Given this list of marker genes VEZF1, TMPO, SLC4A1, GATA6, CBS, TNNT2, NKX2-5, PRDX1, DMD (dystrophin), TAF1A, ACTN2, SGCD, TCAP, FLNC, KCNN4, JAK2, MYH7, SCN5A, LMOD2, ABCC9, MMACHC, CITED2, TTR, KCNJ2, MYL4, KCNQ1, TPM1, MYPN, SERPINC1, HABP2, NUP155, LMNA, GET3, LDB3, PSEN1, DES, DSP, GATA5, HRG, KCNE2 (potassium voltage-gated channel subfamily E regulatory subunit 2), GATA4, PIEZO1, PRKAR1A, SDHA, TNNI3, RAF1, KCNE1, F13A1, TLL1, ADA2, FKTN, KIF20A, MYH6, PPCS (phosphopantothenoylcysteine synthetase), RPL3L, SCN3B, GJA5, EPOR, KCNA5, NKX2-6, DOLK, HAND2, BAG3, F2, UBA1, CAP2 (NCBI Gene Id 10486), TTN, ANKRD1, SCN4B, BAG5, RBM20, DSG2, KCNJ5, CSRP3, TAFAZZIN, PRDM16, LAMA4, PSEN2, KCNK3, MT-CYB, MTRR, PIGA, CRYAB, JPH2, MYBPC3, GATAD1, PITX2, TNNC1, F12, PLN, FHL2, TXNRD2, MTHFR, PDE11A, KCNJ3, VCL, NPPA, SCN2B, NEXN, ACTC1, SCN1B, here is a description of the gene set: The formation of a blood clot inside a blood vessel that subsequently travels through the blood stream from the site where it formed to another location in the body, generally leading to vascular occlusion at the distant site. Thromboembolism species: Homo sapiens Human Gene Set: HP_THROMBOEMBOLISM